The following is a description of a gene set: species: Mus musculus Mouse Gene Set: GOBP_NEGATIVE_REGULATION_OF_NLRP3_INFLAMMASOME_COMPLEX_ASSEMBLY Any process that stops, prevents or reduces the frequency, rate or extent of NLRP3 inflammasome complex assembly., and this is the list of marker genes: Cptp, Trim30a, Zdhhc12 (zinc finger, DHHC domain containing 12), Fbxl2, Igtp, Trim31, Nlrc3, Sirt2, Irgm2, Lamp2, Abhd17a (NCBI Gene Id 76403), Trem2, Mefv, Hspa8, Irgm1, Csnk1a1